Given this list of marker genes Chd1, Rad51c, Neil3, Smarca2, Mcm5, Rad50, Recql5, Mcm9, Tent4b, Polh, Chd8, Pole, Rad9a, Pold3, Ercc1, Top6bl, Msh3, Rexo2, Tet1, Anxa1, Aen, Ercc3, Fan1, Xrcc6, Top3b, Pold4, Ttf2, Msh5, Smarca1, Exo1, Trex2, Rev1, Tdg-ps, Dnmt1, Pld3, Btaf1, Rfc3, Polq, Hfm1, Rad51, Arid1a, Rev3l, Fen1, Chd9, Smarca4, Ddx3x, Dnase2a, Hmga2, Dqx1, Pola2, Exog, Mlh1, Chd3, Hmga1b, Nav2, Rad51b, Terc (telomerase RNA component), Ruvbl2 (NCBI Gene Id 20174), Ptges3-ps, Nipbl, Ankle1, Msh4, Dffb, Aste1, Setmar, Dnmt3a, Cdk7, Tep1, Mau2, Meiob, Top3a, D1Pas1, Pot1a, Wapl, Ddx1, N4bp2, Blm, Mpg, Tdg, Hmga1, Polg, Gtf2f2, Mcm8, Rfc5, Terf1, Ercc6, Hltf, Ercc5, Poll (NCBI Gene Id 80659), Chd5, Smug1, Atrx, Xrcc2, Isg20, Chd2, Dynll1, Mcm6, Mcm7, Mbd4, Xrcc4, Dhx30, Ung, Rbbp8, Top2a, Tet3, Poln, Chtf8, Dhx9, Dmc1, Dkc1, Dnase1l3, Msh6, Myd88 (myeloid differentiation primary response gene 88), Lig1, Rad51d, Dnase1, Dclre1a, Rtel1, Mgme1, Poli, Lig4, Xrcc1, Smarca5, Pms2, Endog, Aplf, Smarcal1, Aptx, Helb, Xrcc3, Xrcc5, Endov, Alkbh3, Pola1, Eme2, Rad54l, Dclre1b, N6amt1, Rps3, Chtf18, Dnmt3l, Rad17 (RAD17 checkpoint clamp loader component), Rfc2, Ercc6l, Alkbh2, Trp53, Mcm3, Mre11a, Ruvbl1, Zranb3, Dicer1, Brip1, Tefm, Ten1 (NCBI Gene Id 69535), Pif1, Dscc1, Upf1, Pold1, Ino80, Recql, Alkbh1 (alkB homolog 1, histone H2A dioxygenase), Acd, Hnrnpa1, Chrac1, Ddx11, Top1mt, Polg2, Dnase1l1, Mutyh, Npm2, Pot1b, Top1, Ogg1, Ighmbp2, Exd2, Top2b, Zgrf1, Eme1, Mettl4, Chd6, Ptbp1, Ascc3, C1qbp, Smarcad1, Mus81, Bptf, Polb, Primpol, Tert (NCBI Gene Id 21752), Wrnip1, Nme1, Fbh1, Dnase1l2, Mcrs1, Lig3, Pinx1, Msh2 (mutS homolog 2), Tet2, Rad1, Dnmt3b, Chd7, Apex2, Mcm2, Rbbp4, Apex1, Ercc2, Dntt, Polm, Dclre1c, Trex1 (three prime repair exonuclease 1), Rad54l2, Slx1b, Polk, Dffa, Dna2, Ptges3, Mcm4 (NCBI Gene Id 17217), Neil2, Chd4, Wrn, Dhx36, Fancm, Pcna, Bivm, Fto, Terf2, Dnase2b, Twnk, Sub1, Helq, Rfc4, Hmces (NCBI Gene Id 97315), Neil1, Atad5, Rfc1, Supv3l1, Spo11, Pld4, Recql4, Rad54b, Tatdn1, Alkbh4, Tdp1, Gen1, Tdp2, Chd1l, Pgbd5, Rag1, Ercc4, Exo5, G3bp1, Nthl1, Cecr2 (CECR2, histone acetyl-lysine reader), here is a description of the gene set: studied in species Mus musculus Catalytic activity that acts to modify DNA. Mouse Gene Set: GOMF_CATALYTIC_ACTIVITY_ACTING_ON_DNA